The following is a description of a gene set: Any process that modulates the frequency, rate or extent of synaptic vesicle membrane organization. species: Mus musculus Mouse Gene Set: GOBP_REGULATION_OF_SYNAPTIC_VESICLE_MEMBRANE_ORGANIZATION, and this is the list of marker genes: Grik5, Doc2a, Syt5, Erc1, Rims1, Vamp1, Syt2, Cacna1b, Doc2b, Prrt2, Syt11, Doc2g, Cplx3, Syt13, Rph3a, Cplx2, Syt8, Cplx1, Syt7, Cplx4, Rab3a, Erc2, Rims2 (NCBI Gene Id 72660), Rimbp2, Syt4, Syt1, Rph3al, Syt9